Given this list of marker genes SLC3A1, SLC7A9 (NCBI Gene Id 1461), here is a description of the gene set: part of: SLC transporter disorders Reactome Pathway: Defective amino acid transport by SLC7A9 causes cystinuria (CSNU) studied in species Homo sapiens SLC7A9 encodes the b(0,+)-type amino acid transporter 1 BAT1. As a heterodimer with SLC3A1 in the plasma membrane, SLC7A9 mediates the high-affinity, sodium-independent transport of cystine (CySS-, the oxidised form of L-cysteine) and dibasic amino acids in exchange for neutral amino acids and is thought to be responsible for the reabsorption of CySS- and dibasic amino acids in the kidney tubule (Schweikhard & Ziegler 2012). Defects in SLC7A9 (or SLC3A1) can cause cystinuria (CSNU; MIM:220100), an autosomal disorder characterised by impaired renal reabsorption of cystine and dibasic amino acids. The low solubility of cystine causes the formation of calculi in the urinary tract resulting in obstructive uropathy, pyelonephritis, and, rarely, renal failure. Cystinuria is subcategorised as type A (mutations on SLC3A1) and type B (mutations on SLC7A9).